The following is a description of a gene set: species: Mus musculus Genes predicted to be targets of miRBase v22 microRNA mmu_miR_320_3p in miRDB v6.0 with MirTarget v4 prediction scores > 80 (high confidence targets). from publication Chen Y, Wang X (PMID 31504780) Mouse Gene Set: MIR_320_3P, and this is the list of marker genes: Nudt5, Ube3a, Tcf24, Rab14, Zfp512, Itsn1, Ints7, Exo1, Rgs17, Cert1, Cdh20, Cxadr, Itm2b, Fgf12, Armcx2, Mical2, Hipk3, Gxylt1, Zfp597, Dusp3 (dual specificity phosphatase 3 (vaccinia virus phosphatase VH1-related)), Kcns3, Rc3h1 (NCBI Gene Id 96936), Cxxc4, Mindy2, Ell2, Pcdha6, Pcdha4, Fem1b, Abhd13, Pcdha11, Bmpr2, Smarcc1, Nexmif, Pcdhac1, Bdh1, Cpd, Blcap, Hycc2, Nlrp4g, Mpp3, Gpbp1, Pcdha8, Onecut2, Grhl1 (NCBI Gene Id 195733), Ccser2, Mindy3, Zfyve16, Prps1, Spopl, Bmi1, Pcdha12, Pbx1, Rap1a, Ermn, Pcdha3, Ttll4, Naa20, Cdk6, Ncoa4, Zswim6, Qsox2, Ubr3, Pcdha1, Zranb2, Pcdha2, Pak5, Prkcg, Sav1, Atp11a, Caprin1, Pcdha7, Fhip2a, Pcdhac2, Pcdha10, Csnk1g3, Mdm2, Gopc, Cnksr2, Fgd4, Ccser1, Rasa1, Dcp1a, Scai, Evx2, Msi2, Eif2d, Gdap1, Eny2, Neil2, Sdk1, Tmprss11g, Kdm7a, Cpeb1, Pcdh19, Cdk13, Rassf2, Cxcl14, Arl8b, Ide, Aldh1l2, Trim41, Napg, Ndufv2, Creb5, Fign (NCBI Gene Id 60344), Otud7b, Lrrtm1, Golt1b, Hivep2, Plppr1, Dhdds, Xpo1, Nufip2, Mecp2, Unkl, Sptssb, Dmd, Klhl23, Zfp281 (NCBI Gene Id 226442), Fam199x, Ubqln1, Arhgap44, Pbx3, Cemip2, Igf2bp3, Sfrp1, Etnk1, Ipo5, Pcdha5, Unc13c, Otud6b, Gnai1, Itsn2, Lrp6, Cyth1, Mex3b, Fam149b (NCBI Gene Id 218805), Abcc5, Smurf2, Hspa4, Spry4 (NCBI Gene Id 328944), Pyroxd1, Triap1, Tmem47, Atg14, Icmt, Zxdc, Agfg1, Tmem255a, Ap3m1, Rlig1, Rmdn3, Ctsr, Ppm1b, Magi1, Las1l, Dcc (NCBI Gene Id 77607), Dzip3, Pcdha9, Arpp19, Armc1, Wipf3, Ctsl, Gulp1, Tiprl, Rai2, Cnot6l, Mllt3, Mob1b, Pabir1, Satb2, Ppp3r2, Pdzd8, Srsf12, Mtdh, Zc3h7b, Pfkm, Cdh2, Tmem64, Ikzf2, Pigk, Ncor1, Gabpb2, Rap2a, Pan3, Ereg, Trabd2b, Cux1, Trap1, Tbx4, Hsf3, Hoxa10, Bod1l, Il17a, Ctbs, Des, Peli2, Ywhah, Btg2, Tmem108, Tmem263